The following is a description of a gene set: Human Gene Set: KAYO_CALORIE_RESTRICTION_MUSCLE_DN In laboratory rodents, caloric restriction (CR) retards several age-dependent physiological and biochemical changes in skeletal muscle, including increased steady-state levels of oxidative damage to lipids, DNA, and proteins. We have previously used high-density oligonucleotide arrays to show that CR can prevent or delay most of the major age-related transcriptional alterations in the gastrocnemius muscle of C57BL/6 mice. Here we report the effects of aging and adult-onset CR on the gene expression profile of genes in the vastus lateralis muscle from rhesus monkeys. Gene expression analysis of aged rhesus monkeys (mean age of 26 years) was compared with that of young animals (mean age of 8 years). Aging resulted in a selective up-regulation of transcripts involved in inflammation and oxidative stress, and a down-regulation of genes involved in mitochondrial electron transport and oxidative phosphorylation. Middle-aged monkeys (mean age of 20 years) subjected to CR since early adulthood (mean age of 11 years) were studied to determine the gene expression profile induced by CR. CR resulted in an up-regulation of cytoskeletal protein-encoding genes, and also a decrease in the expression of genes involved in mitochondrial bioenergetics. Surprisingly, we did not observe any evidence for an inhibitory effect of adult-onset CR on age-related changes in gene expression. These results indicate that the induction of an oxidative stress-induced transcriptional response may be a common feature of aging in skeletal muscle of rodents and primates, but the extent to which CR modifies these responses may be species-specific. Downregulated in the vastus lateralis muscle of middle aged rhesus monkeys subjected to caloric restriction since young adulthood vs age matched controls from publication Kayo T, Allison DB, Weindruch R, Prolla TA (PMID 11309484) species: Homo sapiens, and this is the list of marker genes: G0S2, AXIN1, VDAC2, CDR2L, RAB4A, NOS2, BMP6, HLA-DMA (NCBI Gene Id 3108), DDR1, KAT5, MBTPS1, GOLGA3, RPSA, SNRNP27, KRT5, KDM5C, GOT2, MYOC, MNAT1 (MNAT1 component of CDK activating kinase), ACAA2, BAK1, COL2A1, PSG9, ACTN1, SERINC3, POLR2I (RNA polymerase II subunit I), NNT, RAPGEF3, PRPS1L1, CRYAA, RAB2A, GNAQ, VLDLR, CYC1, SMOX, CYP2D7, MRPL23, NDUFV2, RHCE, DDO, SLC23A2, PEX19, ACR, HADH, TAFAZZIN, CGREF1, ATP5F1B, RGS3, UQCRC2, MPI, ERG, TNP1, ATF6B, P2RY4, UQCRB, MDH1, CKMT2, HSD17B1P1, COX8A, APOA4, TSPAN7, TSNAX, ECH1, COPB2, HADHB, HRAS, PIAS1, RUNX2, RRS1, DDX17, CREM, PCDHGB7, POU2F2, ELL, FBP2, RANBP1, ABCC2, COX4I1, PNLIPRP2, GLI3, RCAN1, TUG1, ACHE, COMMD1, DYNLT1, DBI, ADCY2